The following is a description of a gene set: Neighborhood of IFNA1 interferon, alpha 1 in the MORF expression compendium Human Gene Set: MORF_IFNA1 Neighborhood of IFNA1 species: Homo sapiens, and this is the list of marker genes: IL7, TTN, ATP2B2, FAM110B, COQ7, GUCY2C, ZNF202, CAMK4, LRP4, ERC2-IT1, OR10H3, OTC, SERPINA4, ZNF157, ABCB1 (NCBI Gene Id 5243), GNG4, FLRT2 (NCBI Gene Id 9822), CLCN4, HSD3B2, DBT, NEB, DAZL, SIM2, PTPRB, TBX19, CDH8, NTNG2, KLRC4, SLC26A4, NR3C2, IFNA10, BRD4, FBXL4, JADE3, LGI1, CCN6, RREB1, P2RY10, MDM2, AMMECR1, EXOC4, IFNW1, KPNA1, AKAP3, CALN1, HCRTR2, GPR171, SPRR2C, GABRB2, COL14A1, RAD51D, TBXT, ABCB10, ROR2, DOK5, GCM1, IFNA8, HSPA1L, ATXN3, SUPT3H, ATF6B, RYR1, R3HCC1L, SIX6, PHOX2B, SULT4A1, F2RL1, ITGBL1, PLPPR4, PDE4D, NPAS2, PPM1E, RB1CC1, MAP2K7, ADAMTSL3, FGF2, FSHR, BMP10, FUT1, ZSCAN26, GCA, IFNA2, POLR1HASP, TNK1, SGCD, FOSL1, APOBEC1, IFNA14, CCR3, RYR3, CDC73, DMD, NHEJ1, TLL1, MON2, SLC4A8, STAC, PART1, COLGALT2, FZD5, DMPK, PHLDB1, COL8A1 (NCBI Gene Id 57086), GPR18, GRIK1 (NCBI Gene Id 2897), RXRG, S100A5 (NCBI Gene Id 6276), HNF1A, CADM4, DDX52, CDR1, CAMTA1 (calmodulin binding transcription activator 1), MAP3K1, SLC46A3, GPR19, RORB, HTR1E, PDE6A, NR1I2, DNAJC22, IGKV7-3, TPD52L1, LECT2, KRT2, MAGEA8, SPA17, MYH2, GUCY2F, PCDHB17P, ZNF132 (zinc finger protein 132), ATP4B, POU6F2, CYP2E1, NPFF, CDKL5, TMEM26, OR2B6, FGA, ATP10B, COL19A1 (NCBI Gene Id 7950), ST8SIA1, TTTY1, SLC6A2, SMYD3, ITIH3, ADAM20, LIPC (lipase C, hepatic type), EDIL3, ABO, CLCN3, PRKCA, EYA1, IL4, ZNF141, GJB5, GYPA, CTSB, AOC4P, ATP8B1, ZBTB40, LDB3, PGM3, CACNA2D1, ZBTB14, CEP162, PCM1, CRHR1, MC5R (melanocortin 5 receptor), SLC15A1, MAP2, TRIM24, PSD, ATF2, B4GALT6, LILRA1, KCNA5, RSC1A1, IPO9, C6 (NCBI Gene Id 12274), DRD1, CFH, FGF18, GLRA3, PTPRR, ADGRL2, MLLT10, KRT34, CMKLR2 (chemerin chemokine-like receptor 2), IFNA1, RBBP7 (NCBI Gene Id 5931), JRKL, ISL1, NOL4, CXCL5, HEPH, PVR, PSG1, TSSK2, CPB2, PAX6, MPP3, THPO, MAGEA9, SLC17A1, ERCC4